The following is a description of a gene set: part of: DNA Repair studied in species Homo sapiens Reactome Pathway: Nucleotide Excision Repair Nucleotide excision repair (NER) was first described in the model organism E. coli in the early 1960s as a process whereby bulky base damage is enzymatically removed from DNA, facilitating the recovery of DNA synthesis and cell survival. Deficient NER processes have been identified from the cells of cancer-prone patients with different variants of xeroderma pigmentosum (XP), trichothiodystrophy (TTD), and Cockayne's syndrome. The XP cells exhibit an ultraviolet radiation hypersensitivity that leads to a hypermutability response to UV, offering a direct connection between deficient NER, increased mutation rate, and cancer. While the NER pathway in prokaryotes is unique, the pathway utilized in yeast and higher eukaryotes is highly conserved.<BR>NER is involved in the repair of bulky adducts in DNA, such as UV-induced photo lesions (both 6-4 photoproducts (6-4 PPDs) and cyclobutane pyrimidine dimers (CPDs)), as well as chemical adducts formed from exposure to aflatoxin, benzopyrene and other genotoxic agents. Specific proteins have been identified that participate in base damage recognition, cleavage of the damaged strand on both sides of the lesion, and excision of the oligonucleotide bearing the lesion. Reparative DNA synthesis and ligation restore the strand to its original state.<BR>NER consists of two related pathways called global genome nucleotide excision repair (GG-NER) and transcription-coupled nucleotide excision repair (TC-NER). The pathways differ in the way in which DNA damage is initially recognized, but the majority of the participating molecules are shared between these two branches of NER. GG-NER is transcription-independent, removing lesions from non-coding DNA strands, as well as coding DNA strands that are not being actively transcribed. TC-NER repairs damage in transcribed strands of active genes.<BR>Several of the proteins involved in NER are key components of the basal transcription complex TFIIH. An ubiquitin ligase complex composed of DDB1, CUL4A or CUL4B and RBX1 participates in both GG-NER and TC-NER, implying an important role of ubiquitination in NER regulation. The establishment of mutant mouse models for NER genes and other DNA repair-related genes has been useful in demonstrating the associations between NER defects and cancer.<BR>For past and recent reviews of nucleotide excision repair, please refer to Lindahl and Wood 1998, Friedberg et al. 2002, Christmann et al. 2003, Hanawalt and Spivak 2008, Marteijn et al. 2014)., and this is the list of marker genes: POLR2J, UBE2I, RAD23B, POLD2, PPIE, RUVBL1, POLE4, SUMO3, POLR2I, USP7, SUMO1, COPS7B, RPA1, COPS7A, RFC1, POLK, RPS27A, RPA3, PIAS3, COPS6, ERCC4, UBC, INO80E, MCRS1, RFC5, ERCC2, NFRKB, RFC2, POLR2G, ACTB, ERCC1, ELL, INO80B, PRPF19, POLR2E, POLD4, UBB, ACTR8, PIAS1, COPS3, GTF2H4, POLR2F, CDK7, POLR2D, RBX1, RPA2, COPS8, RFC4, PARP1, TFPT, YY1, POLE3, XRCC1, UVSSA, GTF2H1, POLD3, ERCC8, INO80C, INO80, LIG3, POLE, GTF2H2, ZNF830, COPS4, XPC, LIG1, ERCC6, XAB2, POLR2L, GPS1 (G protein pathway suppressor 1), POLR2H, DDB2, POLR2K (RNA polymerase II, I and III subunit K), COPS2, SUMO2, XPA, ISY1, TCEA1, RAD23A, UBE2N (ubiquitin conjugating enzyme E2 N), PARP2, CUL4A, PCNA, POLD1, CUL4B, ACTL6A, USP45 (NCBI Gene Id 85015), UBA52, POLR2A, COPS5, POLE2 (NCBI Gene Id 5427), INO80D, POLR2C, ERCC5, GTF2H5, GTF2H3, RFC3, CCNH, RNF111, CETN2, MNAT1, CHD1L, AQR, ERCC3, ACTR5, UBE2V2 (NCBI Gene Id 7336), POLR2B, DDB1